Given this list of marker genes PINK1, SRC, TOMM6, CSNK2B, UBB, UBE2L3, FUNDC1, VDAC2, TOMM7, UBE2D3, UBE2V1, PGAM5, MFN2, ULK1, MAP1LC3B, UBA52, SQSTM1, RPS27A, CSNK2A2, UBE2N (ubiquitin conjugating enzyme E2 N), CSNK2A1, TOMM70, MAP1LC3A, TOMM20, UBE2D2, TOMM22, TBK1, PRKN, ATG9A, MTERF3, MFN1, VDAC1, ATG5 (NCBI Gene Id 9474), TOMM5, ATG12, OPTN (NCBI Gene Id 337928), UBC, VDAC3, TOMM40, here is a description of the gene set: part of: Selective autophagy species: Homo sapiens Reactome Pathway: Mitophagy Mitophagy is a specific form of autophagy where mitochondria are specifically targeted for degradation by autophagolysosomes. In mammals there are a number of known mechanisms of mitophagy. One ensures maternal inheritance of mitochondrial DNA through the elimination of sperm derived mitochondria. A second is elimination of functional mitochondria during erythrocyte maturation and eye lens maturation. It is established that the outer mitochondrial membrane receptor Nix (or Bnip3l) and autophagosome associated protein LC3 are important for mitochondrial degradation in erythrocytes. A third mechanism is driven by the PINK1 and Parkin (PRKN) proteins. PRKN is recruited to the mitochondria when the mitochondrial membrane potential is reduced due to uncoupling, thereby initiating mitophagy.